Given this list of marker genes SYT17, ZNF890P, HEATR9, TPBG, ADAMTS7, COL5A3, CHD5, TNNC1, ATP13A4, LINC03124, MFGE8, SPRY1, OCM, TRIM74 (NCBI Gene Id 378108), GSDMA, ATG9B, LMO7-AS1, TRBJ2-4, HSPG2, SPRY2, NRCAM, MMP15, IL23R, CYP4F12, KCNJ5-AS1, NOG, CACNA1I, LINC00612, SHANK1, FXYD2, DPEP3, MIR635, COL5A1, STYK1, NDRG4, here is a description of the gene set: studied in species Homo sapiens Genes down-regulated in peripheral blood mononuclear cell vaccinated with AS03 adjuvant vs phosphate-bufferred saline in adults (19-39) after exposure to inactivated monovalent influenza A/Indonesia/05/2005 H5N1 split-virus vaccine, time point 1D, administered i.m. BACKGROUND: Adjuvant System 03 (AS03) markedly enhances responses to influenza A/H5N1 vaccines, but the mechanisms of this enhancement are incompletely understood. METHODS: Using ribonucleic acid sequencing on peripheral blood mononuclear cells (PBMCs) from AS03-adjuvanted and unadjuvanted inactivated H5N1 vaccine recipients, we identified differentially expressed genes, enriched pathways, and genes that correlated with serologic responses. We compared bulk PBMC findings with our previously published assessments of flow-sorted immune cell types. RESULTS: AS03-adjuvanted vaccine induced the strongest differential signals on day 1 postvaccination, activating multiple innate immune pathways including interferon and JAK-STAT signaling, Fcgamma receptor (FcgammaR)-mediated phagocytosis, and antigen processing and presentation. Changes in signal transduction and immunoglobulin genes predicted peak hemagglutinin inhibition (HAI) titers. Compared with individual immune cell types, activated PBMC genes and pathways were most similar to innate immune cells. However, several pathways were unique to PBMCs, and several pathways identified in individual cell types were absent in PBMCs. CONCLUSIONS: Transcriptomic analysis of PBMCs after AS03-adjuvanted H5N1 vaccination revealed early activation of innate immune signaling, including a 5- to 8-fold upregulation of Fc-gammaR1A/1B/1C genes. Several early gene responses were correlated with HAI titer, indicating links with the adaptive immune response. Although PBMCs and cell-specific results shared key innate immune signals, unique signals were identified by both approaches. from publication Howard LM, Goll JB, Jensen TL, Hoek KL, Prasad N, Gelber CE, Levy SE, Joyce S, Link AJ, Creech CB, Edwards KM (PMID 30566602) Human Gene Set: HOWARD_PBMC_INACT_MONOV_INFLUENZA_A_INDONESIA_05_2005_H5N1_AGE_19_39YO_AS03_ADJUVANT_VS_BUFFER_1DY_DN